Given this list of marker genes NEXMIF, LAS1L, HEXB, MT-ND6, MAPT, MT-TL1, TDO2, MT-CO2, MT-CO1, UBAP2L (ubiquitin associated protein 2 like), MT-TH, CHD3, MT-ND5, AP4E1 (adaptor related protein complex 4 subunit epsilon 1), NSD1, KANSL1, MT-TW, MT-CO3, MT-ND1, MT-TF, MT-TS2, MT-TQ, MT-ND4 (NCBI Gene Id 4538), SCYL1, here is a description of the gene set: Stuttering Human Gene Set: HP_STUTTERING species: Homo sapiens Disruptions in the production of speech sounds, with involuntary repetitions of words or parts of words, prolongations of speech sounds, or complete blockage of speech production for several seconds.